Given this list of marker genes PON2, SELENOP, SOX10, S100A1, TSC22D4, QKI, OAF, NCAM1, LGALS1, SERPINE2, SCN9A, NPY, ANGPTL7, APOC1, PSAP, TUBA1A, CHPT1, LGI4, STMN1, CNP, CHL1, GPR37L1, NRN1, SEMA3B, SNCG, CRYAB, SPTBN1, AATK, C2orf88, SPARC, KCNMB4, MT3, PDLIM4, SORBS2, PMP2, GAS7 (growth arrest specific 7), SPP1, MARCKS, ZEB2, PLEKHA4, FXYD1, APP, CADM2, MPZ, GFRA3, CST5, SCN7A, ITGB8, SOD3 (NCBI Gene Id 6649), S100A10, VIM, PLAC9, RGCC, PTGDS, CMTM5, NAT8L, PCDH9, FADS2, NUDT4, PMP22, FADS3, ARHGAP15, PLEKHB1, MT2A, TIMP3, PRNP, PTN, POLR2F, IFI6, SLC35F1, CD59, CLU, TTYH1, CDH19, NRXN1, S100B, MFGE8, FADS1, NR2F1, SEPTIN7, FOXD3-AS1, NDRG2, MT1M, ERBB3, FRZB, TSPAN8, ITIH5, LPL, TMEM176B, NTRK2, PLP1, METRN, GPM6B, IFITM3, ABCA8, APOE, EDIL3, SCD, AP1S2, VWA1, BEX3, MIA, MT1E, SCRG1, CLIC4, RARRES2, RNASE1, ALDH1A1, TMOD2, DBI (diazepam binding inhibitor, acyl-CoA binding protein), DKK3 (dickkopf WNT signaling pathway inhibitor 3), CST3, NICOL1, TMEM176A, CNN3, here is a description of the gene set: from publication Durante MA, Kurtenbach S, Sargi ZB, Harbour JW, Choi R, Kurtenbach S, Goss GM, Matsunami H, Goldstein BJ (PMID 32066986) Human Gene Set: DURANTE_ADULT_OLFACTORY_NEUROEPITHELIUM_OLFACTORY_ENSHEATHING_GLIA studied in species Homo sapiens